The following is a description of a gene set: species: Homo sapiens Immune cell-specific expression is one indication of the importance of a gene's role in the immune response. In order to identify such patterns, we set out to broadly profile gene expression in a variety of immune cells. from publication Abbas AR, Baldwin D, Ma Y, Ouyang W, Gurney A, Martin F, Fong S, van Lookeren Campagne M, Godowski P, Williams PM, Chan AC, Clark HF (PMID 15789058) Human Gene Set: GSE22886_UNSTIM_VS_IL2_STIM_NKCELL_DN Genes down-regulated in comparison of unstimulated NK cells versus those stimulated with IL2 at 16 h., and this is the list of marker genes: NOP10, GGCT, SPOUT1, IMPDH2, ABCF2, TP53, PSMD14, IL4R, CSE1L, TUBA3D, PRMT3, TIPIN, RPA3, EIF2S1, UBE2N, UBE2M, RBM14, PRDX3, PKM, CLN6, PTPN7, ADARB1, RANBP1, SCLY, DIMT1, SYNE3, PAICS, PRC1, DCTPP1, BCCIP, KLHL2, ERCC6L, CHEK1, SUV39H1, EEF1E1, LDLR, TMEM97, ESPL1, TSEN2, HSPD1, GEM, CRELD2, TUBB3, NUP107, TUBA1B, HMMR, CCT7, STX3, CDC25A (cell division cycle 25A), CTPS1, NASP, HSPA9, USP14, GINS2, FLT3LG, ENO1, ARHGDIA (Rho GDP dissociation inhibitor alpha), CDK4, PPRC1, BRCA2 (BRCA2 DNA repair associated), TUBA1C, SLC39A14, EXOSC2, APOO, PSMD6 (NCBI Gene Id 9861), EBNA1BP2, NOL6, HNRNPAB, WDR1, BYSL, CISH, HNRNPC, MRPL35, CDK2AP2, UBE2S, VIM, TUBB4B, LTA, MLH1 (mutL homolog 1), PCNA, SHCBP1, FABP5, CDK6, POLD2, NME1, SHMT2, NUP188, UCK2, H2AX, PSMB5, SLC1A5, TUBG1, NUP93, NAA15, RRS1, STK17B, MRPL17, POP1, TCP1, ORC3, PA2G4, TRIP13, DPP4, TXNRD1, DDX39A, EXO1, SNU13, P4HB, SQLE, IARS1, LMNB2, ALDH18A1, AUNIP, PDSS1, SLCO4A1, RAD23A, DONSON, IPO4, B3GALNT1, DHCR7, STIP1, CD69, SMARCB1, CDC20, WDR12, MCUR1, MCM4, ASNS, POLR2H, TUBB, SMG9, FASN, MCM6, EPRS1, JPT2, IFRD2, BCL2L1, CCND2, CCT6A, MRPL39, CKS1B, TEX30 (NCBI Gene Id 93081), CDC45, CCT2, MMD, STOML2, XRCC5, WDR3, PSMD1, GRWD1, BLM, DKC1, MRPL3, COPS3, CKS2, CDT1, GMNN, CCT8, SARS1, ECHDC1, DDOST, PIGV (phosphatidylinositol glycan anchor biosynthesis class V), TFDP1, CDCA4, GINS3, FEN1, PAK1IP1, RFC4, NDUFA6, MCM2, TLN1, SENP3, IPO7, MAT2A, CYP51A1, SYNCRIP, CSNK2B, CENPS, KPNA2, CDC37, DNAJC9, ATP1A1, CDC6, SREBF2, RAN, XPOT, MTHFD1, TRIM28, SLC16A1, MCM7, PRPF4, TPM4 (tropomyosin 4), SNRPB, SLC7A1, DCLRE1A, MSMO1, LTB, ACACA, MCM10, MLEC